The following is a description of a gene set: species: Homo sapiens Reactome Pathway: Signal Transduction Signal transduction is a process in which extracellular signals elicit changes in cell state and activity. Transmembrane receptors sense changes in the cellular environment by binding ligands, such as hormones and growth factors, or reacting to other types of stimuli, such as light. Stimulation of transmembrane receptors leads to their conformational change which propagates the signal to the intracellular environment by activating downstream signaling cascades. Depending on the cellular context, this may impact cellular proliferation, differentiation, and survival. On the organism level, signal transduction regulates overall growth and behavior.<br>Receptor tyrosine kinases (RTKs) transmit extracellular signals by phosphorylating their protein partners on conserved tyrosine residues. Some of the best studied RTKs are EGFR, FGFR, insulin receptor, NGF, PDGF and VEGF. RTKs frequently activate downstream signaling through RAF/MAP kinases, AKT and PLC- gamma, which ultimately results in changes in gene expression and cellular metabolism. <br>Receptor serine/threonine kinases of the TGF-beta family, such as TGF-beta receptors and BMP receptors, transmit extracellular signals by phosphorylating regulatory SMAD proteins on conserved serine and threonine residues. This leads to formation of complexes of regulatory SMADs and SMAD4, which translocate to the nucleus where they act as transcription factors. <br>WNT receptors transmit their signal through beta-catenin. In the absence of ligand, beta-catenin is constitutively degraded in a ubiquitin-dependent manner. WNT receptor stimulation releases beta-catenin from the destruction complex, allowing it to translocate to the nucleus where it acts as a transcriptional regulator. WNT receptors were originally classified as G-protein coupled receptors (GPCRs). Although they are structurally related, GPCRs primarily transmit their signals through G-proteins, which are trimers of alpha, beta and gamma subunits. When a GPCR is activated, it acts as a guanine nucleotide exchange factor, catalyzing GDP to GTP exchange on the G-alpha subunit of the G protein and its dissociation from the gamma-beta heterodimer. The G-alpha subunit regulates the activity of adenylate cyclase, while the gamma-beta heterodimer can activate AKT and PLC signaling. <br>NOTCH receptors are activated by transmembrane ligands expressed on neighboring cells, which results in cleavage of NOTCH receptor and release of its intracellular domain. NOTCH intracellular domain translocates to the nucleus where it acts as a transcription factor. <br>Integrins are activated by extracellular matrix components, such as fibronectin and collagen, leading to conformational change and clustering of integrins on the cell surface. This results in activation of integrin-linked kinase and other cytosolic kinases and, in co-operation with RTK signaling, regulates survival, proliferation and cell shape and adhesion. <br>Besides inducing changes in gene expression and cellular metabolism, extracellular signals that trigger the activation of Rho GTP-ases can trigger changes in the organization of cytoskeleton, thereby regulating cell polarity and cell-cell junctions., and this is the list of marker genes: ARHGEF39, MIR21, VEGFC, GDF2, FARP2, ARHGAP9, RGS8, CASP10, LAMTOR2, GPR68, MST1, CTNNBIP1, GSK3B, SAA1, CCL27, MFN1, RHO, SDR16C5, ARHGEF10, EGF, DOK1, FURIN, MYLK, ALDH3A2, ALKAL1, VIP, KRAS, TAB2, SPRED2, CXCL8, DOCK7, H2AX, POLR2D, MIR200B, PSMB1, OXER1, H2AJ, YWHAQ, PRKCD, PDE4D, DIAPH3, FAF2, CCDC187, IL3RA, CASP8, SHMT2, STUB1 (STIP1 homology and U-box containing protein 1), PHC1, MOSPD2, PIK3R6, CREBBP, ARHGAP30, CSN2, FER, FGF5, WWTR1, PTPN1, CENPP (centromere protein P), PLPPR3, DOCK8, MMP3, LYN, SPINT1, TAS2R20, TULP3, ARC, KIF2B, MUC20, DUSP6, TUBA3C, NRAS, AAMP, RHOD (NCBI Gene Id 29984), C3AR1, AP2S1, PPP2CA, CSNK1E, SSTR3, SEMA4F, CHRM2, PLPPR5, ROCK2, RND3, CBX8, EED (embryonic ectoderm development), WNT11, KITLG, RCE1, TAS1R1, RANBP9, MIR26A1, RHOH, VCL, PSMC2 (proteasome 26S subunit, ATPase 2, NCBI Gene Id 5701), ESRP1, IQGAP1, COL6A1, GNG4, PDE3A, KIF5B, DOCK2, COL3A1, FGD2, RYK, ABCD3, WNT2B, POLR2L, RDH11, PCP2, ARHGAP22, WASL, BRAP, IFT57, DDX5, RPS27, KIF2C, ADAP1, RBBP4, CENPQ, STMN2, NOTUM, CBY1, FGFR4, CCL20, P2RY4, KCTD6, CCNK, KAT2A (lysine acetyltransferase 2A), LRRK2, MECOM, PRKG2, AP2B1, PSMA4, GIPC1, GNAT2, ARHGAP1, HDAC4, PDE4B, GFRA1, STX5, P2RY1, CENPC, ANLN, BAX, SOCS1, KSR2, VAV1, XCL2, WWP1, CXCL10, LAMA5, ADD3, DUSP5, BRS3, RHOA, DKK2, H2AB1, VEGFD, MUC13, GAS1, ARHGAP26, DUSP16, SCD, BCL2, GLI2, CLTB, CALM1, ITGB3BP, PAG1, SHH, F2RL3, SRMS, FASN, ADH1A, PDE8B, ADCY10, DGKI, NMUR2, OTULIN, N, NR2E1, CHD3, CBFB (core-binding factor subunit beta), PORCN, JUP, PDE10A, H2BC11, RGS10, PROKR1, SOX9, OPN4, CCNT1 (NCBI Gene Id 904), ST3GAL6, H2BC9, FPR2, OPRM1, ATP6V0B (NCBI Gene Id 533), PPP2R1A, ARHGEF3, MCF2L, TBK1, ROR1, ARHGAP5, CD274, FOXO3, GARRE1, TAS2R43, TIMP2 (NCBI Gene Id 7077), PLEKHG5, SCRIB, CNR2, OTUD7B, LIMK2, TCF3, RPS6, TAAR1, BASP1, CDC25C, PTENP1, GTF2F1, MIR206, BCAR1, PDE1C, BIRC5, M, MIR200C, PMCH, HIF1A, SKA2, RFNG, E2F4, EZH2, CENPS, ARHGEF40, POMC, MC1R, PRAG1, SOST, BCL2L11, AGTR2, PLIN1, GRM1, TRADD, SH2B3, H2AC6, DRD3, EGR3, B9D2, PSMD13, NLK (nemo like kinase), RXFP2, KIDINS220, DYNC1I2 (dynein cytoplasmic 1 intermediate chain 2), GABBR1 (NCBI Gene Id 2550), PSMB3, ACKR2, CCR1 (C-C motif chemokine receptor 1), TUBB3, TCF4, WASF3, IL32 (NCBI Gene Id 9235), AKAP13, AHCTF1, FZD6, STEAP3, S100A8, RBX1, PTGER2, MTA3, VWF, KNTC1, ZW10, PLCB1, RCC2, RXRG, RGS16, C1QBP, MTNR1B, SMAD5, SQSTM1, ATP6V0A1, RCOR1, PIP4K2A, TLE1, TGFB1, FADD, KMT2B, ADRA1D, TGFBR1, TJP1, ARHGAP42, ADRB1, TNFRSF10D, TUBA4B, TMPO, GCGR, SCTR, PPP3CA (protein phosphatase 3 catalytic subunit alpha), GNAI2, SRGAP1, EPS15, ATP6V0E2, MEN1, MED1, TAAR5, SOS1, WNT5A, ITGA2, ECE2, PIK3CA, CXCL11, GPR132, CXCL6, ARHGEF5, TRAK1, GRM3, PPP5C, BCL9L, TAS2R3, AP2A1, YWHAH, CAB39L, ZDHHC7, PPP1R12B, AVPR1A, CDC73, RAMP3, WDR5, DHH, DUSP9, NTF3, DVL2, RPTOR, PSMC1, OXGR1, DERL2, ID4, TRHR, ULK3, ALDH1A2, MIB2, WDR19, THBS2, BDNF, CDK1, SOX17, EPN1, TGIF1, TUBB4A, RDH14, PSEN2, SRC, PDGFD, H2BC3, HEBP1, GPR183, RIPK1, PSMC4, ARHGAP45, GNAS, FGFBP3, SPTBN4, TCIRG1, ARPC1A, MIR23B, ADCY2, H2BC15, SWAP70, MIR17, RND2, ADAM17, FARP1, MLN, GLI3, NDEL1, PYGO2, ABCG5, NRTN, FGF3, DOCK11, DLAT, CNKSR2, ACVRL1, SH3KBP1, MIR92b, PPP1CA, HNRNPF, PPP2R5A, KDM4C, IHH, SHC2, CCR8, HDAC7 (histone deacetylase 7), WASF1, PRKCA, NUP107 (NCBI Gene Id 57122), CXCL1 (C-X-C motif chemokine ligand 1), SEPTIN7, PHLPP1, RASGRP2, KDM4B, TUBB2B, PLCB3, RRAGC, DRC4, RHOU, PTGER3, IGF2, INSR, GLI1, OPN1MW, CENPI, DAB2IP, WIPF2, DVL3, MTMR4 (NCBI Gene Id 9110), CHUK, POLR2A, BDKRB1, DIAPH2, CCND1, GDNF, ARHGEF28, SOX13, RASA1, TLE3, PLEKHG1, FOXO4, USP2, ITGB1, P2RY14, AGO3, KIF7, CENPU, SPOP, RPGRIP1L (NCBI Gene Id 23322), MAPK13, JUN, NCOR1, LIN7B, RSPO4, POTEE, TAS2R8, GRB2, TPM4, RAP1A, KIF14, PTPN3, RGL1, PDHA1, MPP7, CD55, WLS, PSMA2, FLRT2, CXCR2, GRIN2D, POLR2K, CCR2, CXCL16, DGKE, PIK3R3, FGFR2c, GNAO1, ATP6V1A, PMEPA1, PIK3R5, ACVR2A, DLC1, TACR3, ELF3, TAX1BP1, KIF3A, NCSTN, DUSP2, YES1, IRS1, NTRK3, SSTR1, CASP2, CDC42BPA, CDC42EP4, GNG5, GPR37, PSMD8, ROPN1, H2BC17, YAP1, GSK3A, CER1, HCRTR2, ARHGAP24, DNM2, TAS2R16, BUB3, CSF2RA (colony stimulating factor 2 receptor subunit alpha), GPR45, TAS2R38, FLT3, NPBWR1, MXD4, ADCY1, IGF2BP1, MIR181C, PDE1A, ADRA2A, CHN2, CDC14A, CXCR5, HTR2A, RGS18, MC2R, RDH5, CDC20, MYH14, PTBP1, GHRHR (NCBI Gene Id 2692), PIK3CB, SMURF2, BUB1B, TFDP2, TAS2R7, FGFR2, RASGEF1A, CAMK2B, ADAM12, DRD4, RASGRP4, MIR34C, MAMLD1, MAPK12, PAQR3, GIPR, ADM, FGFR2b, HTR1B, ADORA2A, CKAP4, ARPC1B, FMNL1, TLN1, DUSP1, TIA1, PTGER1, PTPRJ (NCBI Gene Id 5795), CHD8, ITGB8, FZD1, SMO, HRH4, MTOR, SHKBP1, PKN2, DKK1, PDE6A, CIT, MIR22, PLXNB1, SFRP2, CLASP2, GNB4, S1PR1, XCL1, PTPRZ1, DPY30, WIPF1, OPN3, RASGRP3, IFT122, PF4, ASH2L, BCL2L1 (BCL2 like 1), GPR39, PEAK1, ARHGAP32, PRKACB, TUBA8, ITGA3, NAB1, CCT2, LYL1, TNK2, CRHR2, PTH1R, RPS6KB1, ARHGAP18, KIF18A, ACTR2, GPSM3, NEDD8, BCL9, GNG8, UACA, CCL28 (C-C motif chemokine ligand 28), GPR83, TAAR3P, CDC37, HEY2, MTMR1 (NCBI Gene Id 8776), PRICKLE1, FNTB, TRIO, CPNE8, CDK5R1, PTPN11, TAS1R2, COL5A3, IL2RA, GNAT3, IGF1, DOCK9, KREMEN2, FNTA, PSMA1, CBX6, SPDL1, TRIM33, CCR9, ITPR2, PIK3R4, CORT, AKR1C3, DUSP8, WDR35, GNA15, ARHGAP33, ARHGEF1, CKAP5, RXRA, MCHR1, RGS6, RAPGEF4, DTX2, FST, ERCC6L, DLG5, FFAR1, GPR55, RGS22, ADGRE3, FGD5, ACTC1, DOCK3, C5AR2, FAM83B (NCBI Gene Id 222584), NCOA3, EEPD1, P2RY2, TACC3, RRH, MFNG, FAM13A, FOXO6, STAM2, PSMD14, EIF4G1, HDAC1, CAVIN1, CRHBP, PLA2G4A, MLST8, LATS1, PFN2, PLCB4, COL2A1, GOPC, DVL1, AMIGO2, TAX1BP3, ESR1, HTR1E, NLN, NDC80, FGF16, FBN1, EGFR, ID1, AATF, TMEM87A, DLG4, POGLUT1, ACTN2, CAPZB, MIR27B, PTPN13, CDON, RICTOR, COL4A2, DNMBP, TLE4, ATP6V0D2, NAB2, STARD8 (NCBI Gene Id 9754), EGR1 (NCBI Gene Id 1958), PLTP, CSNK2A2, NRG1, NDUFS3, ICMT, SMAD6, MIR449B (microRNA 449b), ATP6V0C, ARHGAP31, STAG2, AVPR2, PIK3R1, NFKB1, VEGFB, MIR214, BTK, CDC14B, CX3CL1, PAK1, MIR33B, SH3GL2, TNFRSF10B, POLR2I, ARHGAP6, VIM, RASAL1, RHOF, APH1A, DOCK5, DLK1 (delta like non-canonical Notch ligand 1, NCBI Gene Id 8788), USP15, NCF4, TGFB2 (NCBI Gene Id 7042, transforming growth factor beta 2), PSMA5, SUZ12, STAT3, F2R, POLR2C, GPBAR1, LAMC3, FOS, FGFBP2, HECW1, NPHP4, TAS2R19, CYLD, KLC2, AGO2, MAP2K1, FRAT2, POLR2J, APOE, LIMK1, RAMP2, MACO1, ARAP2, ABI2, MIR150, EFCAB7, SYDE1, VGF, GMIP, KAT5, WNT7B, HTR1F, CAMK2A, CDH5, TAS2R50, CCL25 (C-C motif chemokine ligand 25), PDYN, MIRLET7A1, HNRNPH1, NTF4, KISS1, RGS5, PROK1, PSMC3, CXCL13, RPS6KA5, CDC42EP3, BDKRB2, PICALM, PCDH7, GPHB5, SOCS3, NRG2, HSPB1, NOTCH4, POLR2E, GPR35, NPS, FNBP1, IL2, VIPR1, HES1, CCL1, ARHGEF15, PGRMC2, GNGT1, S100B, SMAD4, TNKS2, DGKG, TAS1R3, MIR106B, DNAL4, CCNC, TRH, ITGB5 (integrin subunit beta 5), NOTCH2NLA, PDK4, PPP2R1B, RIT2, PRKCH, MYO9B, PRLHR, ITGB6, MTA1, ATP6V1H, HGF, DOCK10, THBS4, CCRL2, ARHGEF10L, MAML2, SOWAHC, DDRGK1, MAP3K11, CCDC88A, PSEN1, TUBA3D, TGFBR2, PLCB2, PRKAR2B, PDK2, WWOX, HTR1D, GNA13 (NCBI Gene Id 147219), MYD88, CXCL3, APH1B, ATF2, IL6ST, ADORA3, MEF2C, FAS, FZD7, FFAR4, ADRM1, NEURL1B, NGEF, CBX2, PDE3B, ZWINT, RELA, DOCK6, ECE1, GRK6, ALDH8A1, TAS2R5, SMAD1, THBS1, PRKAR1A, GALNT3, RGS20, TAAR2, ADAM10, INHBB, PTGIR, SOX3, DHRS4, HDAC6, MYB, KANK1 (KN motif and ankyrin repeat domains 1), PTPRF, PSMB5, RALA, CYBA, BLTP3B, UCN3, CXXC5, KBTBD7, PLPPR4, LPAR4, ARL2, SMARCA4, H2BC12, LGR4, KLC4 (kinesin light chain 4), PSMB2, TFF1, HEY1, DGKZ, SFPQ, SPARC, FERMT2, OPRL1, GPR25, NCAM1, P2RY13, RAB9A, PNOC, TERT, WNT9B, S100A9, GABRG3, DOCK4, IQGAP3, CREB1, CCT7, RAP1GDS1, CFLAR (CASP8 and FADD like apoptosis regulator), BAMBI, ATP6V1G3, FGB, WNT6, THBS3, NRG3, FGF6, PSMD7, OPRK1, PDGFRA, MIS12, PRKAA1, GNG10, IKBKG, OPN1LW, PRKCB, SCUBE2, DST, ARMCX3, GPR37L1, RHPN1, SEL1L, PPARD, CCDC88C, SKA1, IL2RB, LAMTOR4, IL3, SMPD2, SPTB, TLE5, PSMB6, MYL9, CALCRL, WNT1, WASF2, EMC3, GRB7, FGF10, SORCS3, E2F1, ABL1, ELMO2, SH3GL1, GNAI1, IRAK1, MAPKAP1, SIRT6, ERBB2, CENPE, ALK, PSMD3, SOX7, CHRM4, DGKH, ARHGAP15, ZAP70, RHOBTB3, LTBP1, P2RY6, TGIF2, PTPRA, PLPPR1, RTKN, CPD, BAIAP2L1, IFT140, RGR, SKP1, KLC1 (NCBI Gene Id 3831), TRAF1, PSMD1, APOC4, CFTR, KDM1A, SMAD2, TTC21B, LTBP2, HGS, SPATA2, EDNRB, PLXND1, H2AZ2, ARHGAP11B, C5, RLN3, UCN2, NUMB, ITPR3, SPEN, LRRC1, MDM2, SH3PXD2A, VEGFA, ETV4, VPS26A, NRIP1, LHB, APOC1, MIR19A, WIF1, PARD6B, NRP2, ARL13B, MYH9, XCR1 (NCBI Gene Id 2829), PPP2R5D, MAF1 (MAF1 homolog, negative regulator of RNA polymerase III), STAT1 (NCBI Gene Id 6772), PHC2, LGR5, DUSP3, DBN1, RGS9, PTPN7, PHIP, ARAP1, PEA15, XPO1, H2BC4, RANBP10 (RAN binding protein 10), GATAD2A (NCBI Gene Id 54815), RACGAP1, NR5A2, SMURF1, TNFRSF1A, PRKAG2 (protein kinase AMP-activated non-catalytic subunit gamma 2), SPPL2B, GRM6, ANXA1, CTBP2, SPOPL, GRM7, CXCR6, NDE1, RASGRP1, POU2F1, MAPK14, CCNE1, STOM, STRAP, E2F5, SMAD9, MAP2K2, RGS19, DBT, FGF19, CHRM3, APLNR, LBR, RHEB, TNFAIP1, ARPC2, TSHR, HRH3, FZD9, USF1, SLC4A7, WNT10A, PAK3, MMP10, FASLG, INS, F3, KSR1, MAPK8, PRKX, WNT9A (Wnt family member 9A), DZIP1, UTS2B, CBL, ARL4C, ATP6V1B1, FYN (NCBI Gene Id 2534), EMD, NCF2, ARHGAP23, GPAM, PDE6B, APOD, LINGO1, STK11, GLP2R, IL5RA (interleukin 5 receptor subunit alpha), THEM4, H2BC12L, HTR7, INCENP, CENPO, GRAP, MAPKAPK5, NEURL1, FPR3 (formyl peptide receptor 3), CUL1, ABHD6, RASA3, GRK2, AGO4, TRAF6, STAT5A, NOTCH3, PTH2, NTSR1, SCFD1, PTPRS, USP4, TRIB1, RBMX (NCBI Gene Id 8258), RARB, FAM83A, PTPRO, DUSP4, KLHL12, TNRC6A, OPHN1, PSMD11, RGS17, PTGER4, MIR33A, CHRM5, RXFP3, TJP2, NOX3, LAMA4, CXCL9, TACR2, PTGDR2, SMC3, EIF4B, BAG4, TRIM27, MTA2, GPR15, POFUT1, MCHR2, GPR32, MIR25, TUBB1, MYL12B, NSMAF, FABP6, PPY, ADCY6, CXCL5, GPNMB, CCT6A, MAPRE1, TUBB8B, REST, CDC42EP1, LGR6, CARM1, NDUFA5, IRS2, ATP6AP1, ARHGAP40, AMOT, CENPF, POLR2G, PTK2, HCAR3, EDN2, IL1RL1, TAS2R31, DRAP1, GNB3, BMP10 (NCBI Gene Id 27302), ARHGEF19, RXRB, ATP2A1, ARFGAP2, CHEK1, ACVR2B, RGS21, ATP6V0A2, VCP (valosin containing protein), S1PR4, GRM8, STBD1, NOXA1, ADGRE2, HES5, EDNRA, TBL1X, PGK1, PSPN, WNT16, PRMT1, RAB4B, ADGRE5, GNRH1, INSL5, KNG1, SNX3 (sorting nexin 3), TAOK3, CDK9, CASP9, FSHB, LAMTOR1, TFRC, WNT8B, USP17L2, MMP9, GRIN1, CCL4, VANGL1, POLR2H, ARPC3, EDN3, RPS6KA3, LRRC7, FOXH1, RING1, OS9, CSNK2B, CYP26A1 (NCBI Gene Id 1592), GAB2, CSF2, WNT10B, PDE4A, PDHA2, WDR91, ZNF512B, SEM1, ARHGEF37, ARHGEF12, CCP110, PIK3AP1, UBE2D2, CCL3, CENPN, COL27A1, PTK6, RAMP1, NPY4R, FGF9, ADM2, MAD1L1, CAMK2D, APBB1IP, KDM3A, GPER1, DRD5 (dopamine receptor D5), ALDH1A1, FGF1, ABCG1, SH2B2, PDE4C, FKBP5, RAPGEF3 (Rap guanine nucleotide exchange factor 3), PAK2, GHSR, ELANE, FAM83D, KNL1, GHRH, ABHD17B, JAG2, ARHGEF38, HBEGF, CENPH, EPOR, ARHGDIB (NCBI Gene Id 397), UBE2D3, FLNA, MIR449A, NR4A1, CHN1, TGFB3, NTRK2, IDE, NCKAP1L, HGFAC, TFF3, DYNC1H1, RHOT2 (ras homolog family member T2), RLN2, MST1R, NSL1, SPPL2A, PRKAR2A, AXL, ACTG1, ECT2, CYFIP2, MYOD1, ATP6V0E1, TAS2R45, RNF31, SOX2, GABRA1, SPTAN1, GNAT1, TSC1, COL9A2, CCL4L1, GNA14, STRN, SRRM1, PSMC6, PLEKHG4B, APC, NRP1, ATP6V1E1, NCOR2, FILIP1, H3C15, TAOK1, SNAP23, CCL17, KDM1B, PPP2CB, GPHA2, F2RL2, COL1A2, CRK, ARPC5, NISCH, BMPR1B, ZNRF3, GRM4, RAG2, PPP2R5B, SST, NBEA, GPR65, SOX4, FAM91A1, RPS6KB2, NPBWR2, SIN3A (SIN3 transcription regulator family member A), MAPK7, TAS2R9, OTUD3, WNT3, CRH, SPRED3, GPR27, BMI1, ATP6V1G1, ARHGAP28, CD19, FRS3, ARHGEF35, SHOC2, XIAP, PLCG2, GAST, STK3, TAS2R13, STK4, SPTBN5, YY1, MCF2, PTGES3, ITGB3, KAT2B, DEF6, RASAL2, GNAZ, PRKAA2, PBX1, H2AC4, F2, WDR11, MET, CTNND1, TAS2R60, CYP26B1, MADD, DOCK1, GRIN2B, NMU, BRAF, UTS2, SPINT2, PDE8A, ARFGAP3, JAG1, USP7 (ubiquitin specific peptidase 7), NMUR1, OTUD1, PCSK6 (proprotein convertase subtilisin/kexin type 6), RAB6A, GFRA2, RUNX1, EPAS1, RHOJ, ELK1, CCKBR, RANGAP1, P4HB, NPY5R, PELP1, FNBP1L, APOC2, FGF18, MAP2K5, PDHB, PPP1R12A, PIP5K1B, PPID, HCRT, SYVN1, DUSP7, SYNGAP1, WNT7A, COL4A4, KREMEN1, SHB (NCBI Gene Id 6461), PTHLH, FCER2, BIRC3, AMHR2, RRAGD, RRAS2, NFKBIA, CEP97, UGT1A3, CXCL12, RGL2, BMPR1A, LAMA1, CRABP2, PLK1, SAV1, STRADB, KLB, TCF7L1, STRADA, FLRT1, IL6R, PREX1, SOX6, IQCE, RBCK1, RSPO3, PROKR2, SMPD3, PFN1, WIPF3, PDE11A, NF2, RASAL3, UL36, SP1, NTS (NCBI Gene Id 96646), RHOBTB1, ICOS, NOTCH2, RBPJ, ITPR1, DACT1, NCK2, ADGRE1, SHARPIN, FGD4, UTS2R, H4C1 (H4 clustered histone 1), USP8, MTNR1A, MFN2, EPS15L1, HTR1A, IL6, GPR31, GIT2, KLK2, ABR, FOXO1, WDR6, KLK3, TUBA1B (NCBI Gene Id 88851), PRKAR1B, TRAK2, PSMB4, EPHA2, POLR2F, ROCK1 (Rho associated coiled-coil containing protein kinase 1), SPRY1, E2F3, DAGLA, SFN, IL2RG, DLG3, GNRHR2, RIPK2, PRKG1, JAK2, MEMO1, NCF1, UHMK1, BMP2, ADCY4, TNS4, AP2M1, DLL4 (delta like canonical Notch ligand 4, NCBI Gene Id 54567), GGA3, ABCA1 (ATP binding cassette subfamily A member 1), IAPP, FOSB, NMS, PRKCI, LTB4R, FGD3, GPR4, GALR3, MYO9A, XK, TUBB2A, TRPC6 (NCBI Gene Id 7225), PDE5A, BTRC, PRKACG, PPP3CB (NCBI Gene Id 5532), INTU, TAS2R1 (taste 2 receptor member 1), IFT52, MIR26B, PTPN6, H3-3A, KPNA2 (karyopherin subunit alpha 2), NCKAP1 (NCK associated protein 1), FAM169A, AXIN2, PML, CALCB, EPGN, CDKN1B, IQGAP2, CENPL, CHD4, CENPA, SSTR4, CCNT2, MIR19B1, WDR83, CDKN2B, CDC42SE2, CSNK1A1, MC3R, FSTL3, ITCH, TACR1, WWP2, CTNNA1, PDGFA, NPW, GABRG2, NR3C1, HDAC11, TAC3, FABP5, RPS6KA1, ARHGEF25, DGKK, FLT3LG, C3, ACTB, CXXC4, AKT1S1, GZMB, PRKCG, IKBKE, OXT, DYNC1I1, CKB, TRAT1, ADCY5, YWHAG, GTF2A2, RGS14, NR1H2, SRGAP3, GOLGA8R, INSL3, MKS1 (MKS transition zone complex subunit 1), UCHL5, RAD21, PIP4K2C, AVP, H2AC20 (H2A clustered histone 20), H3C1, GFOD1 (Gfo/Idh/MocA-like oxidoreductase domain containing 1), SPC25, PTK2B, ARAP3, LEP, NCK1, PPP1CB, GNG7, PDK1, CAMK4, ARHGAP20, ARRB2, GNG11, SGO1, MRAS, TAS2R39, SH2B1, MYLIP, VMA22, FGFR3, FZD3, CD86, PMF1, MKRN1, MTX1, RND1, PRKACA, CAV1, PLXNA1 (plexin A1), PLEKHG4, TNRC6B, MIR205, CDKN1A, GATAD2B, MRGPRD, BCR, ADCYAP1, KCTD13, GNG12, CCL7, SNW1, JUND, HHAT (hedgehog acyltransferase), ARHGAP19, USP21, HRH1, SH3BP1, MIR34A, CCR5, FLT1, FFAR2, SMAD3, MAPK4, GRP, TXNL1, TRAF2, TEX2, NUF2, CAMKK2, GNB5, MAG, DRD2, GNG3, KLC3, STK38, CAV2, NCOA2, LRP5, HTR2C, QRFP, OCRL, HSP90AB1, TPM3, DDX4, TEK, ROR2, ID2, EVC2, PCSK5, CRABP1, LAMC2, SFRP1 (secreted frizzled related protein 1), VHL, KHDRBS1, B4GALT1, COL9A3, FGF23, DLGAP5, LAMC1, IGF1R, TAS2R14, NELFB, ACKR3, HHIP, COPS2, NTRK1, CFL1 (cofilin 1), CBX4, SPRED1, H3-4, CCR7, CCL2, SSTR2, TCF12, PRKCE, MAS1, DLD, NEDD4L, PTCRA, ID3, SMAD7, TAS2R42, KHDRBS2 (KH RNA binding domain containing, signal transduction associated 2), LATS2, ITGA5, MEF2A, LINC01139, MAPK6, ADRB3, ST3GAL4, NPSR1, OXTR, NEFL, JUNB, KDR, LPAR6 (lysophosphatidic acid receptor 6), PAK6, LEO1, LPAR3, TNFSF10, TFDP1, CTTN, H2BC1, STAP2, RBBP5, ARHGEF18, TUBA3E, ADRA2C, TIMP1, STK10, MSI2, CUL3 (cullin 3), RGS11, H2AC18, PARD3, RHOQ, ARHGAP12, FGF22, NOX1, P2RY11, TP53, NUP85, APP, DNM1, HNRNPC (heterogeneous nuclear ribonucleoprotein C), AKT2, TBP, GAL, DSG2, CDH1, PENK, CTNNB1, FZD8, MGLL, PGR, CLIP3, WWC1, MIR93, SH2D2A, TAAR9, NSFL1C, YWHAE, NOTCH2NLC, STIP1, NCBP2, GPR84, MAML3, UBC, LRIG1, PRKAG3, TAS2R4, SYK, NOG, DGKD, RHOV (ras homolog family member V), BAIAP2L2, GIP, PLG, PDPK1, BTC, PAK4, CCL5, PRKAB1, NHS, GNA12, CGA, RALGDS, WNT5B, PIK3C3, CALCA, TRRAP, GABRQ, ABHD17C, F2RL1, PAFAH1B1, CSF2RB, MIR302A, RAG1, HCAR2, TIAM1, MARK3, PTCH2, PPP3CC, WNT8A, CYSLTR1, PPP1R14A, DNMT1, FFAR3, RAP1B, ABHD12 (NCBI Gene Id 26090), LAMB3, LEMD3, ARHGEF26, KL, ACKR1, DGKA, CGN (NCBI Gene Id 57530), TRPC7, LAMTOR5, SPTBN2, CHRM1, CCR10, TIAM2, ESYT1, RBBP6, PPP1CC, MMP14, CCK, PTGDR, PEBP1, KEL, ARHGAP39, TNF, ATP6V1F (NCBI Gene Id 9296), CDC42BPB, HCRTR1, GNA11, RGS4 (NCBI Gene Id 5999, regulator of G protein signaling 4), WDR81, GPSM2, USP34, ACTR3, NGF, DHRS9, ERBIN, FGF8, DSP, GRM5, PTH2R, ZDHHC21, NOTCH2NLB, PXN, UBE2L3, PSAP, CXCL2, PHLPP2, SOCS6, ARHGEF11, RAB9B, ARHGAP11A, CD80, DNM3, BRK1, ALS2, DAAM1, COL11A1, FGFRL1 (fibroblast growth factor receptor like 1), QRFPR, HDAC10, H2BC5, PTPN18, CCR4, LAMA3, CDK5, DSG1, IRAK4, ADRA1B, NFATC1, ADCY7, AMH, ZWILCH, IKZF1, SENP1, IL5, MAPKAPK2, HDAC3 (NCBI Gene Id 8841), RSPO2, GFRA3, ZRANB1, COPS4, EBAG9, FGF20, PSMA7, HSP90AA1, CCR6, AMOTL2, ANKLE2, SPATA13, KTN1, NOTCH2NLR, FGFR1, GREB1, COL4A5, PSMC5, RACK1, CCKAR, BUB1, ARHGDIG (NCBI Gene Id 398), PRR5, CENPT, ZFYVE16, SPTBN1, NCKIPSD, SALL4, RPS27A, EP300, HSPE1, CXCR4, PRKAB2, FGF17 (fibroblast growth factor 17), LTK, ELMO1, SPC24, SEH1L, NIPSNAP2, VRK2 (VRK serine/threonine kinase 2), GNAI3, MIR144, CAMKK1, CTSD, KDM4A, CNR1, PTPN2, PDGFB, PLD2, GRK3, SUCNR1, ANGPT1, CCL22, DGKB, KLF16, PTPRK, PTPN12, DYNLL2 (NCBI Gene Id 140735), FGF7, RUVBL1, RGS1, MMP7, MYO6, SRGAP2, PIP4K2B, CSK, AAAS, CTBP1 (C-terminal binding protein 1), SNAI2, ACVR1B, ATP6V1D, FKBP4, MATK, PKP4, CRKL (NCBI Gene Id 1399), MMP2, GPR161, ULK1, HMOX2, TSHB, ST3GAL3, DGKQ, TRA2B, IRS4, TUBA1A, H2AC14, USP13, ACVR1C, MIR142, HELLS, PTAFR, ARPC4, H2BC13, DNAJB1, GNAL, PTCH1, CSNK2A1 (NCBI Gene Id 1457), SCAI, PROK2 (prokineticin 2), INHBA, FGF2, ATP6V1B2, IER3, EGR2, MIB1, PIK3CD, VIPR2, CX3CR1, ADCYAP1R1, FAM135A, RHOC, ARHGAP44, DAGLB, CD28, EIF4E, DRD1, GRB10, CYSLTR2, LEF1, RGSL1, TNS3, FZD10, ACTN1, PLEKHG2, TMOD3, ACTA2, RXFP4, LHCGR, PARD6A, CAMK2G, HDAC8, ATP6V1E2, GPS1, NPB, PRKAG1, PPBP, NEDD4, GPR18, EVC, TAB1, DYNC1LI1, MMP16 (matrix metallopeptidase 16), PTH, ERBB4, NUP43, RGL3, VAMP3, SPTA1, IL33, CHD1, BIRC2, GFRA4, COL4A3, RGS12, CETP, S1PR5, FES, MOB1A, SKI, TAS2R10, MIR449C, FZD5, COL11A2, TAB3, MYO19, PLCG1, NUP133, RHOBTB2, PPP3R1, TLE2, TUBA1C, NOXO1, ATP6V0A4, UBXN11, COL24A1, GABRB1, HDAC5, MAPK3 (mitogen-activated protein kinase 3), PKN3, DYNC1LI2, TUBB4B, OSBPL11, ATP6V1G2, OPN5, TCF7, CYP26C1, SRY, MIR613 (NCBI Gene Id 693198), ZDHHC9, VPS35, SMC1A, PPARG, NTSR2, SPP1, NOTCH1, PTPRU, HNRNPM, RNF43, S1PR2, CDC42, GOLGA3, DSN1, CALCR, TMED5, RDH10, UBE2D1, ANKRD26, FOXA1, DLG2, ADH1C, DISP2, SH3RF1, RRAGB, YKT6, ITSN1, MIR34B, FLOT2, EPSTI1, PDE6D, PTGFR, H2BC14, TGFA, MT-RNR2, DUSP10, ARHGEF16, GNB2 (G protein subunit beta 2), PYGO1, AKT1, ERLEC1, CNTN1, EIF4EBP1, PKN1, RAPGEF1, RTN4, FLOT1, PDGFRB, NPY1R, TAGAP, ARHGAP17, RIT1, HPN, GREM2, TBXA2R, ADRA1A, FOSL1 (FOS like 1, AP-1 transcription factor subunit), ARHGAP8, COL6A6, ACKR4, OPN1SW, KISS1R, VAPB, MAP3K7, USP9X, GRAP2, GALR2, JAK1, SAMM50 (NCBI Gene Id 25813), GTF2A1, PARP1, CCL19, CCL23, NUP37, COL6A3, SLC1A5, MIR20B, OPTN, FGFBP1, CMA1, AREG, DYNC2H1, FGA, RBBP7, FZD4, RAF1, GNGT2, GHRL, LCK, ARHGAP21, TNKS (NCBI Gene Id 8658), GABBR2, AGTR1, UBB, COL5A2, ARHGEF7, FBXW7, MYF5, VRK3, PDGFC, NR1H3, HTR4, PYY (NCBI Gene Id 5697), RASGRF1, STARD13, TRIB3, SEC13, TCF7L2, ARTN, MAPKAPK3, PDK3, RARG, ATP1B4, PPP2R5C (NCBI Gene Id 63377), DEPDC1B, PRDM4, H2AC7, HRH2, KCTD3, TIAL1, GPC5, PIP5K1A, FRK, ARHGAP10, CLASP1, RAPGEF2, PAK5, SUFU, BCAP31, LTBP4, GPS2, HRAS, ATP6V1C2, ARAF (NCBI Gene Id 369), LRP6, CCR3, P2RY10, ARHGEF33, CITED1, DTX1, SHC1, ITGA8, HCAR1, DNER, GPR17, AVPR1B, FGD1, FPR1, PRKCQ, NMBR, ADORA1, RASGRF2, CLIP1, CAB39, VAPA, DHRS3 (NCBI Gene Id 9249), GATA3, RNF111, GNG13, TUBB6, HTR5A, CLTC, LTBP3, FSTL1, TAAR8, ARHGAP25 (NCBI Gene Id 9938), ATP2A3, RRAD, SCMH1, GNAQ, CNOT6L, KIF5A, GRK5, WNT4, PDHX, ARHGDIA, ATP2A2 (NCBI Gene Id 488), VAV3, TAS2R46, IFT172, ARHGAP27, OPRD1, TUBAL3, ZFYVE9 (NCBI Gene Id 9372), PLD1, GNRH2, SERPINE1, SGK1, TYK2, CHRDL1, LPAR2, YWHAZ, PDE7B, PREX2, RDH13, NUP160, NCOA1, ARHGAP4, DYNLL1, RAC1, GPR176, MBD3, ARHGEF6, USF2, TMED2, HDAC9, MYL6, EVL, SSTR5, MCAM, IFT88, JAK3, TAS2R30, NF1 (NCBI Gene Id 646021), ATN1, ZNF217, TAS2R41, ARHGEF9, PTEN, UCN, SH3GL3, IL1RAP, ADRA2B, YWHAB, NUP98, AMOTL1, MYOG, RGS13, DTX4, CILP, RUNX3, LTB4R2, RALGAPA1, RHOG, WHAMM, PHC3, HTR6 (5-hydroxytryptamine receptor 6), GNG2, MC4R, TEC, RAB7A, CSNK1G2, FSHR, SOS2, CDK4, RGS2, TMEM59, VAV2, SCT, FKBP1A, MC5R, EDN1, FMNL2 (NCBI Gene Id 114793), HEYL, HDAC2, TBL1XR1, EGR4, ITGAV, NUDC, AKAP12, FMNL3, ABCG8, FZD2, LMNB1 (NCBI Gene Id 445266), MYF6, STAG1, FN1, CDK8, RGS3, RGS7, P2RY12, TAAR6 (NCBI Gene Id 6380), MIR20A, LAMB2, STAT6, CMKLR1, ACBD5, LPAR5, COL5A1, ANKFY1, CDK5R2, LYPLA1, COL6A5, LAMB1, PSMB7, CASR, RNF146, GOLGA7, SLK, GPR20, TWF1, BAD, CYBB, VANGL2, EEF2K, LPAR1, RRAGA, SLITRK5, NPFFR1, MLNR, SNAI1, CCND3, AR, SREBF1, PIK3CG, ARRB1, GIT1, COL9A1, TPH1, PSMD6, WAS, PSMA6, KHDRBS3, GCG, CCL16, NPY, PHB1, OFD1, CPSF7, FRS2, AGT, S1PR3, ADCY9, RSPO1, RNF41, TAS2R40, CDK2, ADCY8, WNT3A, LRRC41, SGO2, CYFIP1, KIF2A, TNFAIP3, GAB1, RBL1, PRC1, MAML1, CRHR1, MAPK11, AHCYL1, PLPPR2, HINT2, PSMA3, GJA1, CXCR1, BMPR2, NGFR, ALDH1A3, PPP2R5E, ERBB3, DLG1, RNF20, HNRNPA1, CASP3, RAC3, DKK4, PDE7A, RALB, GNRHR, ARHGEF4, FLRT3, MOB1B, SLITRK3, PRDM1, GFAP, ESR2, RNF2 (ring finger protein 2), PLEKHG6, MRTFA, GPSM1, FRAT1, ARHGEF17, SPHK1 (NCBI Gene Id 8877), WNT2, CCL3L1, AP2A2, UBA52, ABI1, RPS6KA2, PLAT, RASA2, MAPK1, RHPN2, EREG, RDH16, STAT5B, IKBKB, ATF1, VPS29, GPRC6A, OMG, ATP6V0D1, LEPR (NCBI Gene Id 3953), CDC42EP5, MYCN, MYH10, MYH11, PPM1A, NPY2R, ADRB2, TRIP10, PIK3R2, ITSN2, GALR1, SHC3, ITGA2B, PTN, RAB4A, GABRB2, FLT4, STMN1, RET, MIR19B2, PDE2A, FUZ, RARA, CNKSR1, COL6A2, DDX39B, TUBA4A, H2BC26 (NCBI Gene Id 128312), MYC, LETM1, TNFRSF10A, PIP5K1C, LAMA2, RAC2, SKIL, ARF6, ASCL1, ARHGEF2, HTR2B, EPO, ATP6V1C1, ALKAL2, MDK, CDC42EP2, STAM, AGO1, PCK1, SLC38A9, COL1A1, CENPK, RANBP2, TUBB8, INHA, PPP1R15A, FAM13B, PSMD12, NRG4, GTF2F2, TSC2 (NCBI Gene Id 7249), ADCY3, IL17RD, ADORA2B, ABHD17A (abhydrolase domain containing 17A, depalmitoylase), ESRP2, SYDE2, ADH4, DIAPH1, NCBP1 (NCBI Gene Id 4686), CENPM, AKT3, GPR150, CDCA8, FGF4, GPR143, GRM2, OPG199, MEF2D, SPRY2, FGG, TAC1, CXCR3 (C-X-C motif chemokine receptor 3), C5AR1, NMB, PDE6G, GABRB3, MTR, PLIN3, GLP1R, LFNG, PPP1R1B, NET1, BAIAP2, RTN4R, TGFBR3, UBE2M, RXFP1, KIT, KALRN, PDE1B, ARHGAP29, ARHGAP35, RBFOX2, PIN1, ANOS1, ABL2, RASA4, APLN, OBSCN, PSMD2, MIR26A2, TOR1AIP1, COL4A1, H2BC21, TNRC6C, CLTA, ANGPTL3, PLEKHG3, AXIN1, AURKB, GNB1, MAGED1, BEX3, AMER1, F11R, YBX1, MKNK1, GRPR, POLR2B, DLL1, NOS3, NPFF, MOV10, LAT, PRKCZ, RHOB, LMAN1, LAMTOR3, FABP7, PSENEN, CCL11, PGF, CCL21, SRF, EFHD2, CCL13, NPFFR2, PRLH, RALBP1, MIR106A, BOC, RHOT1 (ras homolog family member T1), TRPC3, CUL5, MAD2L1, TLR9 (NCBI Gene Id 54106)